The following is a description of a gene set: studied in species Homo sapiens The controlled release of a substance by a cell or a tissue. Human Gene Set: GOBP_SECRETION, and this is the list of marker genes: TRAPPC11, GNPTAB, ADRA2B, NPSR1, CGA, NEUROG1, DDR1, TNFRSF11A, HLA-DRB1, RAB31, NNAT, CD200, TBX3 (T-box transcription factor 3), POMC (NCBI Gene Id 5443), KCNQ1, PFKM, CCR2, GJA1, CHRNB4, P2RY1, EGF, EXOC6, TARDBP, FGF20, USF2, KCNK9, NOTCH1, TNFSF11, NMUR2, TANGO2, BRSK1 (NCBI Gene Id 84446), ACACB, NCOR2, STAT5A, AGR2, RFX3, RAB40AL, CEL, CHD7, RAB11FIP2, STXBP3, PRKCA, KCNK2, IL12A (interleukin 12A), SLC6A3, SOX11, RAB11FIP5, VPS4A, BCR, HNF1B, BRAF, ISL1, CADPS, FFAR3, PRSS12, CYB5R4, CAD, P2RX7, TSPAN18, RAP1BL, NPVF, HK2, C1QTNF12, PPID, ABCA12, PLA2G2F, SPHK2, TANGO6, SYT5, STX11, SYT11, SYT12, STAM, EXOC6B, XDH, C1QTNF3, MYOF, MIR199A1, ARHGAP44, PDPK1, CCR1, CHRNB2, SERPINE2, CLSTN3, FAM3B, FOXA2, DAB2, GNAZ, SRCIN1, ARFGEF1, MIR199B, KCNA5, LRRK2, CACNA1B, RAB3D, PAK1 (p21 (RAC1) activated kinase 1), GAL, PRICKLE1, SNX10, SMAD2, MMP7, ITGAM, HCRT, STXBP4, LLGL2, ATG5, NLRP5, MIR19B1, ANKRD1, TVP23C, LACRT, STXBP2, LIN7B, PDCD6IP, SCRIB, BEST1, GNAS, SLC29A1, TYRO3, HNF1A, PLA2G3, IL13, SLC16A1, CCKAR, PREPL, SLC6A9, OXT, PPT1, MYOM1, ITSN1, CD74, STX2, EFR3A, FOXO1, CDK5, CYP19A1, BAIAP3, VPS13A, DOC2A (double C2 domain alpha), SRI, SYT3, TVP23B, GNAI1, SYCN, STXBP5L, WNK3, UCN, CA9, HTR4, RAB40A, RAB27A, TFAP2B, OXTR, EXOC3L1, TXLNA, CCND1, PRKCE, SYT17, ACSL3, EXOC3L2, HIP1R, SNX4, SVBP (NCBI Gene Id 374969), ABCG1, NCOA1, CRH, TNFAIP2, NKD2 (NKD inhibitor of WNT signaling pathway 2), CD160, LEP (NCBI Gene Id 3952), CCN3, MT-CO2, TRARG1, CSN3, CCL8, SLC38A2, HTR2C, F2RL2, SIRT4, VEGFA, GPER1, PPP3CB, INHA, RHBDF2, PRL, SCG2, RAC2, GOLPH3 (golgi phosphoprotein 3), GPR15LG, RAB27B, VPS11, PTPRN, MUC2, PDIA4, SDF4 (NCBI Gene Id 82832), PRKACA, DRD2, NPFF, SLC32A1, GIPR, WASH6P, KCNQ3, STEAP3, TFF2, ABCC4, IL1B, MTCO2P12, RAPGEF3, SLC6A4 (NCBI Gene Id 6532), PIK3C2A, SYT8, OXCT1, APBA1, TACR1, VTI1B, B3GLCT, NIBAN2, ANXA3, NPY5R, SYBU, LILRB1, MIR93, TMF1, CTAGE1, CASK, TUNAR, MC4R, S100A13, HRH2 (histamine receptor H2), ACVR1C, SYP, SNAP23, RHBDF1, UNC13A, WDR41, VAMP2, SYNGR1, BMP2, RPH3A, ACVR2B, KCNB1, TLR4, TP73, MTNR1B, SLC4A5, CAV1, SLC51A, IER3IP1, NR1H2, MCU, APOLD1, UBE2Q1, RAB37, CAMK2G, HTR2A, TMEM38B, COMP, XBP1, GHRHR, IL1A, FFAR1, KPNA4, ARL4D, PLA2G2E, HRH3, IRS2, DTNBP1, FKBP1B, MIA3, C1QTNF1, RAB33B, COPG1, STEAP2, GGCX, SLC44A4, PAX8 (NCBI Gene Id 7849), MYH9, NKX6-1, APBB1, PRKG1, FAM3D, NPR1, EDNRB, RAB44, EDN1, PRKCB, TRAF3IP2, NTRK2, SOX4, NRXN1, ANXA2, LMF1, GNAI2, GPR119, FGG, TPRG1L, C1QTNF5, KCNK1, ABCC8, MICAL1, SLC1A5, CLTRN, SUCNR1, AP1S1 (NCBI Gene Id 574017), SYT2, SLC25A22 (NCBI Gene Id 79751), SNPH, KMO, LIF, RIMS3, CD2AP, SEPTIN5, TTN, SLC30A1, UNC13C, GRP, WNT7A, SLC4A8, CSN2, SAA1, GATA1, CDK16, YKT6, HIF1A, CYBA, GUCA1B, STC1, MPC2, TVP23A, VIP, NMU, PARD6A, ACHE, DYNLL1, PRLR, CD38, ARL8B, SLC9B2, BMAL1, MIR30C1 (microRNA 30c-1), MYRIP (NCBI Gene Id 25924), SPI1, FCGR3A, GNRHR, ADA, TRPC4, TNFRSF1A, SGK1, ACSL4, RAP1B, OLFM2, ATP9A, MCTP1, PTPN23, ADORA3, EDN3, SELENOT, GIP, REN, PHPT1, SYN1, FBLN5, ARF6, IL13RA2, FFAR4, PDE8B, SYT4, TPD52, SYT15, ENSA, CTAGE15, APLN, CFTR, CREB1, OSBP, ADCYAP1, HTR1B, PLCB1, PLA2G12A, FURIN, SEPTIN4, RAB11A, CRY2, ATP2A2, NLGN2, IL12B, FUT10, CYP4F2, BRSK2 (NCBI Gene Id 9024), SV2A, SNCA, PLEK, PRKN, MIR33A, GNAO1, INS, NR4A3, VPS35, SYNJ1, CES1, PTGDR, EXOC4, G6PC2, ABCA1, SCAMP5, PNKD, UCN3, CELSR2, BAD, CRHBP, DNAJC5, PCSK5, ERBB4, RAB10, CTAGE4, PIM3, STXBP1, COPS5, CPLANE2, SERGEF, SLC8B1, CWH43, STATH, GJA5, CPLX2, SNF8, TRIM72, F2, MON1A (NCBI Gene Id 84315), SCNN1B, RABEPK, JAK2, CLOCK, USE1, LAT2, GLUD1, TPH1 (tryptophan hydroxylase 1), TSPO, GALR1, STX4, IFNG, RBP4, EXOC8, IL1RAPL1, IL11, TAC1, PROCA1, LAT, BGLAP, CPT1A (carnitine palmitoyltransferase 1A), TGFB3, GAB2, SPP1, TGFB2, FCER1A, CEACAM1, PRKD1, SNX6, PCLO, OR51E2, LAMP1, FBXL20, RAB3B (RAB3B, member RAS oncogene family), KCNN4, STX19, TRPM5, SNX19, AGTR1, NCKAP1L, CKLF, ZP4, RAB40C, CCDC186, RAB21, MIR29B1, CCKBR, VEGFC, FERRY3, ERBB3, AXL, RGCC, PTGES, PRAM1, EXOC5, ERP29, NEGR1, SSTR5, BMP6, ZBED6, NR1D1, DNAJC1, GIT1, CD177, IGF1, PPIA, ALOX5, PCSK6, VAMP7 (vesicle associated membrane protein 7), SV2B, GRXCR1, BSG, ADORA1, CADPS2, S100A8, CHRM5, MIF, VPS4B, SYT1, TRPA1, PRRT2, SMCR8, CBLN1, TREM2, KLRC2, CHMP3, PLA2G12B, PLA2G2D, HADH, WNK4, CDO1, SYT6, RAB3C, PSEN1, ADAM9, AVPR1A, FGF23, STX3, ADCY8, IL1RN, SLC30A8, LLGL1 (NCBI Gene Id 3996), CARTPT, SACM1L, PPFIA2, SLC26A7 (NCBI Gene Id 65015), SYTL5, RAB3A, MIR146A, TGM2, PINK1, PRKCG, GHRH, NAGPA, SYT13, S100A10, ARFIP1, C9orf72, TIFAB, GDNF, RAB1A, RAB5A, FOSL2, ADRA2C, TMEM63A, TMED2 (NCBI Gene Id 10959), SYK, DCANP1, CORO1A, ANO1, RIMS1, RAB11FIP3, FZD4, VDR, PTGS2, UMOD, PTGES2, SYT10, F2R, ITGB2, CBARP, HTR1A, PPFIA3, FGB, ADCY5, F2RL1, SLC22A16, NKG7, SYTL4, SNCG, KIT, CHGA, CORIN, FES, SCN11A, ARFGEF2, NRXN2, TRH, PLA2G6, MECP2, GATA2, SIRT3, GOLPH3L, GPLD1, CD33, FMR1, NR0B2, RHBDD3, SLC26A6, RAB9A, FGA, STK39, CHMP6, SDC1, AVP, AP1G1, ABCB11, RALA, RAB12, TCF7L2, ABAT, DPH3, SNAP25, MYO18A, ILDR1, GSDMD, CBL, PPARG, PTPN11, TCIRG1, NAPA, PLA2G1B, PLA2G2A, EFNA5, PIP5K1C, RAB26, FGFR1, SLC51B, PRKCI, NR1H3, CLNK, RIMS4, NKX3-1, INHBA, GRM4, STXBP6, SLC16A2, LIN7A, GPR68, SPX, PIANP, PFKL, AVPR1B, NEO1, CHRNA3, COPA, CCL3, NPY, EXOC7, GNA11, EQTN, RAB2B, SDC4, EXOC1, UQCC2, CREB3L1, STAT5B, SCAMP1, TRPV6, HMGA2, PLA2R1, TACR2, KCNJ11 (potassium inwardly rectifying channel subfamily J member 11), ANG, PFKFB2, CA2, COPG2, NPY2R, MTTP, EXOC3L4, FCGR2B, CRY1, MIR766, NR1H4, SYTL3, GRK2, MIR19A, SERP1, APBB3, GNAT1, WASH3P, HPS6, IRS1, TMEM167A, FUT11, ACE, TSG101, ABCB1, ADORA2A, TMEM132A, PLA2G2C, NME1, VAMP8, RAB13, PLA2G5, EPHA5, HMGCR, PORCN, IL4R, MEF2C, SYTL2, KCNMB4, DYSF, AP1M2, CLDN2, ORAI1, CSF2, PPP3CA, P2RX1, LGI3, KCNK16, PTGER3, AGT, KLF7 (KLF transcription factor 7), PLA2G4F, IL6, CLASP1, STX17, LYN, AGXT, ARFGAP3, RASL10B, SLC9A4, SDHD, MYO6, BLOC1S3, PFN2, PNPLA8, OSBPL2, ADGRE2, JAGN1, P2RY2, UGT1A3, FGF10, UPRT (NCBI Gene Id 139596), TRPV1, RIC1, ATP13A2, SLC38A3, EXOC2, LRRC8A, GPRC6A, UCP2, ILDR2, REST, CPE, NEURL1, GRM2, P2RX4, FOXF1, PTGDS, RAB25 (NCBI Gene Id 57111), GABBR1 (gamma-aminobutyric acid type B receptor subunit 1), RAB15, ALOX12B, RHBDD1, STX1B, CASR, WNK1, NGF, PRKAR1A, PAFAH1B1, SLC18A3, SCIN, RAB40B, SV2C, ERC2, PPY, SELENOM, CLASP2, SLC12A2, GRM7, RAP1A, AP1B1, AACS, NLGN1, PTPRN2, PIK3CG, NHERF1, BMP8A, OAS2, NAPB, AIMP1, CHRNA4, RFX6, STXBP5, M6PR, WIPF3, WLS (Wnt ligand secretion mediator), DOC2B, RALB, TMEM63B, EXOC3, NRG1, GIPC1, KDM5B, NMB, GATA3, ECRG4, CTAGE8, EIPR1, CXCL12, STX1A, UNC13B (unc-13 homolog B), NTSR1, PCK2, CCL5, ASIC1, MERTK, TMED10, MYB, OSM, MRGPRX2 (NCBI Gene Id 117194), FAM3A, FER1L5, CYP51A1, HGS, SYN2, SYTL1, SNAP29, MICU3, KCNJ8, CAVIN1, GUCA2B, ANK1, TPCN2 (two pore segment channel 2), TRPM4 (NCBI Gene Id 8184), LIN7C, HFE, ABCB4, CALM3, NEUROD1, MYO1G, CDK5R2, PSMD9, NLRP6, MIDN, GCG, INHBB, GPAT4, RAB8B, HCAR2, EXPH5, HAP1, ADORA2B, NOS2, HLA-F, SLC18A2, RCN3, FGR, PICK1, GPR158, DVL1, SLC2A2, FBXO45, SCRN1, RAB11B, SEC24A, MIA2, VSNL1, OPRM1, RABGEF1, GRIK5, TMEM167B, RAB8A, DRD4, FRMD4A, SOCS2, ADTRP, POFUT2, MILR1, RETN, IGHE, RAB7A, FOXB1, RAP1GDS1, ADAM8, CPLX1, MED1, SREBF1, CELA2A (NCBI Gene Id 63036), ANXA1, TM7SF3, MLXIPL, PASK, PLA2G10, RIMS2, RAPGEF4, SNCAIP, CD300A, SLC4A9, FCER1G, TGFB1, CYP4A11, RAB11FIP1, PRF1, SIDT2, MYH10, SNAP47, AP2B1, SYN3, PARK7, TSPOAP1, DNM1L, AQP1, MICAL3, RBM4, TNF, TOR2A, OPRK1, NSF (N-ethylmaleimide sensitive factor, vesicle fusing ATPase), KCNA2, ADAM17, VGF, PDX1, TNFRSF1B, GCK, VAMP3, RAB3GAP1, ADIPOQ, FOXL2, BDKRB2, FGF7, SMPD3, HCK, BLK, KLRF2, SEL1L, BTK, GLP1R, CAPN10, LGALS9, CD84, SDCBP, NKX2-3, CAMK2A, TLR2, IDH2, SYNGR3, ADRA2A, MAFA, RPH3AL, LTBP4, PER2, ITPR1 (inositol 1,4,5-trisphosphate receptor type 1), CTAGE9, ZBTB7B, CPLX3, GPR27, APOE, CHRNA6, CSPG5, CRHR1, MCTP2, CANX, NF1, CHMP2A, SEPTIN1, PDZD11, ENY2, CPLX4, PPARD, SMAD4, RASGRP1, FOXD1, TMEM79, SLC22A2, BLOC1S6, FFAR2, DRD3, HYAL3, TRPV4, PLA2G4A, SYNGR2, CHRM1, SNAPIN, ZP3, GHRL, C2CD2L, KRT20, VPS18, RAF1, NPPB, LTBP2, SYT9, HNF4A, RAC1, RUFY4, WASHC3, NDUFAF2, MTX1 (NCBI Gene Id 4580), CBLN4, CACNB4 (NCBI Gene Id 785), UNC13D, OC90, RSAD2, SCG5, SCT (NCBI Gene Id 6343), P3H1, PIK3CD, AQP5, GDF9, CHRM3, NECAB3, NADK, CTAGE6, ATP7B, OTOF, SLC16A10, GHSR, COMT, SIRT6, GPR151, WASHC1, TFR2, LRP5, SYT7